Given this list of marker genes NRAS, DIAPH1, PTPN18, PTPN12, USP8, AKT2, UBB, MEMO1, NRG2, NRG3, ERBB2, EGFR (NCBI Gene Id 1956), EGF, NRG1, PIK3R1, HBEGF, UBC, ERBB4, SRC, HRAS, PRKCA, KRAS, GRB2, EREG, RHOA, PRKCE, PRKCD, BTC, PIK3CA, CDC37, ERBIN, ERBB3, SHC1, MATK, YES1, AKT3, HSP90AA1, UBA52, RPS27A, STUB1, CUL5, PLCG1, PTK6, AKT1, FYN, SOS1, GAB1, NRG4, RNF41, GRB7, here is a description of the gene set: species: Homo sapiens part of: Signaling by Receptor Tyrosine Kinases ERBB2, also known as HER2 or NEU, is a receptor tyrosine kinase (RTK) belonging to the EGFR family. ERBB2 possesses an extracellular domain that does not bind any known ligand, contrary to other EGFR family members, a single transmembrane domain, and an intracellular domain consisting of an active kinase and a C-tail with multiple tyrosine phosphorylation sites. Inactive ERBB2 is associated with a chaperone heat shock protein 90 (HSP90) and its co-chaperone CDC37. In addition, ERBB2 is associated with ERBB2IP (also known as ERBIN or LAP2), a protein responsible for proper localization of ERBB2. In epithelial cells, ERBB2IP restricts expression of ERBB2 to basolateral plasma membrane regions.<br><br> ERBB2 becomes activated by forming a heterodimer with another ligand-activated EGFR family member, either EGFR, ERBB3 or ERBB4, which is accompanied by dissociation of chaperoning proteins HSP90 and CDC37, as well as ERBB2IP from ERBB2. ERBB2 heterodimers function to promote cell proliferation, cell survival and differentiation, depending on the cellular context. ERBB2 can also be activated by homodimerization when it is overexpressed, in cancer for example. <br><br> In cells expressing both ERBB2 and EGFR, EGF stimulation of EGFR leads to formation of both ERBB2:EGFR heterodimers and EGFR homodimers. Heterodimers of ERBB2 and EGFR trans-autophosphorylate on twelve tyrosine residues, six in the C-tail of EGFR and six in the C-tail of ERBB2 - Y1023, Y1139, Y1196, Y1221, Y1222 and Y1248. Phosphorylated tyrosine residues in the C-tail of EGFR and ERBB2 serve as docking sites for downstream signaling molecules. Three key signaling pathways activated by ERBB2:EGFR heterodimers are RAF/MAP kinase cascade, PI3K-induced AKT signaling, and signaling by phospholipase C gamma (PLCG1). Downregulation of EGFR signaling is mediated by ubiquitin ligase CBL, and is shown under Signaling by EGFR.<br><br> In cells expressing ERBB2 and ERBB3, ERBB3 activated by neuregulin NRG1 or NRG2 binding forms a heterodimer with ERBB2. ERBB3 is the only EGFR family member with no kinase activity, and can only function in heterodimers, with ERBB2 being its preferred heterodimerization partner. After heterodimerization, ERBB2 phosphorylates ten tyrosine residues in the C-tail of ERBB3, Y1054, Y1197, Y1199, Y1222, Y1224, Y1260, Y1262, Y1276, Y1289 and Y1328 that subsequently serve as docking sites for downstream signaling molecules, resulting in activation of PI3K-induced AKT signaling and RAF/MAP kinase cascade. Signaling by ERBB3 is downregulated by the action of RNF41 ubiquitin ligase, also known as NRDP1. <br><br> In cells expressing ERBB2 and ERBB4, ligand stimulated ERBB4 can either homodimerize or form heterodimers with ERBB2, resulting in trans-autophosphorylation of ERBB2 and ERBB4 on C-tail tyrosine residues that will subsequently serve as docking sites for downstream signaling molecules, leading to activation of RAF/MAP kinase cascade and, in the case of ERBB4 CYT1 isoforms, PI3K-induced AKT signaling. Signaling by ERBB4 is downregulated by the action of WWP1 and ITCH ubiquitin ligases, and is shown under Signaling by ERBB4. Reactome Pathway: Signaling by ERBB2